The following is a description of a gene set: Human Gene Set: REACTOME_SIGNALING_BY_NODAL studied in species Homo sapiens Signaling by NODAL, and this is the list of marker genes: CRIPTO, ACVR2B, GDF1, LEFTY2, PCSK6, CER1, SMAD4, FURIN, FOXH1, LEFTY1, ACVR2A, DRAP1, CFC1, ACVR1C, NODAL, MAPK3, SMAD3, DAND5, CRIPTO3, ACVR1B, MAPK1, SMAD2, FOXO3